Given this list of marker genes PODXL, EDN1, WWTR1, EXT1, NOTCH1, PDGFB, MTSS1, PRKX, OSR1, AMPD2, JAG1, WNT9B, GATA3, ADIPOQ, LHX1, WT1, NPHS2, PTPRO, NOTCH2, CD34, MYO1E, CD2AP, LIF, IQGAP1, PROM1, NPHS1, EDNRB, YAP1, FOXJ1, SMO, CTNNB1, SALL1, PAX8, PAX2, KLF15, GPR4, STAT1, ASXL1, EDNRA, CD24, ACTA2, GDNF, BASP1, SIX2, LAMB2, FOXC2, MMP9, MEF2C, MAGI2, GREM1, here is a description of the gene set: Human Gene Set: GOBP_EPITHELIAL_CELL_DIFFERENTIATION_INVOLVED_IN_KIDNEY_DEVELOPMENT The process in which relatively unspecialized cells acquire specialized structural and/or functional features of an epithelial cell that characterize the cells of the kidney as it progresses from its formation to the mature state. species: Homo sapiens